Given this list of marker genes Gabra3, Gabrq, Gabrb3, Gabrg3, Gabrg2, Gabrr3, Gabbr2, Gabbr1, Gabrb2, Gabrb1, Gabra1, Grid1, Gabrr2, Gabra4, Gabrd, Gabra2, Gabre, Gabrp, Gabrr1, Gabra5, Gabrg1, Gabra6, Gpr156, here is a description of the gene set: Mouse Gene Set: GOMF_GABA_RECEPTOR_ACTIVITY Combining with gamma-aminobutyric acid (GABA), and transmitting the signal from one side of the membrane to the other to initiate a change in cell activity. (GABA, 4-aminobutyrate) is an amino acid which acts as a neurotransmitter in some organisms. studied in species Mus musculus